The following is a description of a gene set: part of: Mucopolysaccharidoses species: Homo sapiens Mucopolysaccharidosis III (Sanfilippo syndrome) was described in 1963 by a pediatrician named Sylvester Sanfilippo (J. Pediat. 63: 837838, 1963, no reference). MPS IIIB (Mucopolysaccharidosis type IIIB, MPS IIIB, Sanfilippo syndrome type B; MIM:252920) is an autosomal recessive genetic disorder due to loss of function of alpha-N-acetylglucosaminidase (NAGLU; MIM:609701), involved in the hydrolysis of terminal non-reducing N-acetylglucosamine residues in heparan sulfate (HS) The gene encoding NAGLU was cloned in 1996 by Zhao and colleagues. It contains 6 exons and spans 8.3 kb on chromosome 17q21. MPSIIIB is characterized by severe CNS retardation but only mild somatic disease and death usually occurs in the second or third decade of life. MPS IIIB shows extensive molecular heterogeneity. Reactome Pathway: MPS IIIB - Sanfilippo syndrome B, and this is the list of marker genes: NAGLU